Given this list of marker genes ALX4, GTF2IRD2, GLI2, DTYMK, DYNC2I1, EFNB1 (ephrin B1), PROKR2, SATB2, TBC1D20, CPLX1 (complexin 1), BRCA2, CHST14, HRAS, KISS1, PDPN, ALG8, ARID2, DAZ3, FMR1, ARL6, CHRM3 (cholinergic receptor muscarinic 3), BCOR, KMT5B, TBL2 (NCBI Gene Id 27203), IGBP1, SMC1A (structural maintenance of chromosomes 1A), MESP2, USP7, PHIP, OFD1, UQCC2, PRPS1, PEX12, CLCN3, POLD1, NFIB, MC2R, DPYSL5, STRA6, MRPS28, COMT, DNAJC21, HUWE1, PHACTR1, UBR1, FGF10, DYNC2I2, PSMD12, ARID1B, TRPM3, REST, LZTR1, SOX11, RAB3GAP1, SOX4, YY1, EIF4H, DAZ4, MKRN3, PDE4D, BBS4, CSPP1, CLCN4, PYCR1, PPP1CB, NHLH2, BIN1, MUSK, RPGRIP1L, KMT2E, RAB23, PAX2, TINF2, HPSE2, PIGG, PRKACB, ZBTB20, KDM5C, TRRAP, PPP1R15B, SDCCAG8, DYNC2H1, ATN1, RREB1, BBS9, VPS35L, KIF21A (NCBI Gene Id 80819), FGFRL1, STT3B, KIAA0753, TRIM32, TRIM28, ADAMTS15, PHGDH, VAC14, CCDC22, CYB5A, TRIP13, PRMT7, GTF2IRD1 (GTF2I repeat domain containing 1), PRIM1, COL4A1, OPHN1, KCNAB2, G6PC3, BBIP1, SMOC1, BDNF, MMP23B, XRCC4, IGF2, TAF4, SKI (SKI proto-oncogene), MRAP, SIN3A, TSR2, DUSP6, MADD, FANCD2, GFM2, CC2D2A, LAS1L, NDN, ALDH18A1, PTCH1, HS6ST1, DVL3 (NCBI Gene Id 1857), TIAM1, SEMA3A, SCAPER, LMBR1, WNT3, NCF1, ERCC4, VANGL1, TUBA1A, UBE4B, DVL1, POU3F3, LUZP1, HIBCH, EVC, MAPRE2, GATA5, SEC24C, PNPLA6, RNU4ATAC, SEMA3E (NCBI Gene Id 9723), SLC25A24, PDE6D, HNRNPK, ALDH1A2, FAM149B1, FGFR3, PEX2, LIMK1, RIPPLY2, POLR1A, NNT, ATP6V0A2, MTMR14 (NCBI Gene Id 64419), RAB3GAP2, DNM2 (dynamin 2), MAP2K2, ERCC6, BUB1B, WDR35, LETM1, ASH1L, FGF17, INSL3, GNB2, ITPR1, STX1A, GPR161, FLNB, ESS2, RTTN, XPC, MKS1, PEX14, EBF3, SIM1, EHMT1, NKAP, B3GALNT2, GPC3, TBX4, MBD5, TAF6, BRAF, DDB2, NKX2-6, GNRH1, PIK3C2A, FKRP, CEP120, DLL3, CRPPA (CDP-L-ribitol pyrophosphorylase A), BBS2, ANOS1, ZNF699, PIGA, SPRY4, CAMSAP1, MYF6, ARID1A, EED, CDCA7, MAPK1, RERE, SCYL2, ARCN1, DDX3Y, SOX2, PEX16 (NCBI Gene Id 9409), MAB21L1, NSMF, AR, FARS2, ZFPM2, SRD5A2, SRCAP, FLRT3, SNRPN, PTDSS1, RBMY1A1, PHF8, HSPG2, AKR1C2, GRIN2B, WT1, RIPK4, DDX3X, MAP2K1, BBS10, POLR3A, TPM2 (tropomyosin 2), SPATA22, ARNT2 (NCBI Gene Id 9915), JMJD1C, WNT7B, TOGARAM1, SGPL1, HS2ST1, LFNG, KCNQ1OT1, MKKS, CPLANE1, AKR1C4, SMCHD1, HES7, GP1BB, IFT80, SLC18A3, TMEM231, PHF6, CEP290, NDNF, PAX6, OTX2, HMGA2, RARB, THOC2, ROR2, DEPDC5, CHD7, LARGE1, POMK, SIX6, BUD23, GTF2E2, FANCE, FGFR2, PEX26, DNA2, KAT6A, ATP6V1E1, FRAS1, AHDC1, LIG4 (DNA ligase 4), POMGNT2, CREBBP, UBR7, EBP, GLI3, NOTCH3, NSUN2, HDAC4, HERC2, HESX1, HYMAI (hydatidiform mole associated and imprinted), EIF2S3, UFD1, MAD2L2 (mitotic arrest deficient 2 like 2), LMX1B, OTUD6B, FANCM, RPGRIP1, CDK8, PWAR1, PACS2, MASP1, MYMK, NR5A1, BBS7, H19, AARS1, ATAD3A, MYL11, ERCC3, ANKLE2, CEP19, FREM2, NAA10, RAD51C, ERCC2, FAT4, DHX37, UBE2A, PEX13, WBP4, MID1, ORC4, KISS1R, CDH11, RIT1, DKC1, ABCB7, BICRA (NCBI Gene Id 29998), RFC2, NF1, ABCD4, CDC45, NEDD4L, DGCR8, GNRHR, POMGNT1, MED11, PEX11B, PEX5, MAP3K7, ALKBH8, GRIA2, WNK3, TARS1, DLK1, CITED2, ATRX, MPLKIP, TMEM237, ODC1, BMP4, POLE, HNRNPR, KDR (NCBI Gene Id 3791), KDM3B, CHD4, RXYLT1, WNT5A, BRD4, GDF1, SNORD115-1, WNT7A, NXN, TXNRD2, RBM10, STT3A, RECQL4, DOK7, VPS50, OCRL, FLG, FBXL4, CARS1, RIN2, WWOX, SMAD4, TCF12, RAD51, SMC3, NONO, SETD5, SLX4, SOS1, PPFIBP1, RRAS, CCDC32, GK, FDFT1, DYNC2LI1, TNRC6B, NDUFB7, ABL1, POLR3K, NOTCH2, HNRNPH1, PTPRF, KMT2A, LHX4 (LIM homeobox 4), H4C9, WDR11, RSPO2, MYH3, CCDC174, POLA1, RYR1, SAMD9, POMT2, DGCR2, DPP9, GTF2H5, STXBP1, CTBP1, EP300, HOXD13, PEX3, METTL27 (methyltransferase like 27), MYLK, GATA1, SMS, GLI1, ATR, DDX59, SOX3, BBS5, MAP3K1, SLC16A2, LZTFL1, TBX22, RTL1, AMHR2, UBA1, GMPPB, TACR3, DAZ1, BRIP1, CYP17A1, JAG1, CWC27, BRF1, PLAGL1, OGT, IER3IP1 (NCBI Gene Id 55392), DAG1, LRIG2 (leucine rich repeats and immunoglobulin like domains 2), LHX1, TGDS, PBX1, NAF1, MEG3, MTOR, SIAH1, BBS1, USP9Y, PRDM13, SRY, ZMYM3, KIF7, DDX6, CYP11A1, TWIST2, TCOF1, ARVCF, FBN1, TMEM107, B9D1, POLR1C, GTF2I, PRKAR1A (protein kinase cAMP-dependent type I regulatory subunit alpha), ALG12 (ALG12 alpha-1,6-mannosyltransferase), MRAS, ADARB1, DSE, CILK1, DNMT3A, STAC3, PEX6, TBX3, RORA, AUTS2, IFT74, MEGF8, HBA2, RFWD3, FGF8, TSPYL1, GRB10, INPPL1, HBA1, TTC5, TCTN2, PAX7, FLNA, SPEN (NCBI Gene Id 348488), LSS, PIEZO2, GMNN, RRAS2, FBLN1, ANAPC1, GJA5, GPC4, KLHL15, JAM3, DPAGT1, TCTN3, FBXW7, DNAJC19, RLIM, CFAP418, TMEM67 (NCBI Gene Id 91147), RAC1, SMARCAL1, ESCO2, FLT4, XRCC2, SLC35D1, TBCE, KAT5, POLR1D, PACS1, OCA2, FEZF1, BRCA1, SNORD116-1, GRIP1, AMH, CAMK2A, CHRNG, CDC42, SHOC2, FANCL (FA complementation group L), TTC8 (tetratricopeptide repeat domain 8), KRAS, TCTN1, PAICS, PUM1, IFT27, FUZ, TCF4 (NCBI Gene Id 6925), ORC1, C2CD3, NSD2, DCC, RASA2, KANSL1, NPHP1, DHCR7, PORCN, NUP88, PEX1, SPECC1L, WDR62, NDP, ACBD6, RPL10, SCLT1, PTCH2, B4GAT1, MTM1, MBTPS2, SALL1, NIPBL, SLC26A2, GSC, CDH2, AEBP1, TOPORS, NALCN, SMARCA2, SRA1, SUZ12, HSD3B2, TBL1XR1, WDPCP, BRWD3, SOX9, HIRA, SLC30A7, CCDC141, CD96, ZSWIM6, CDC42BPB, POLR1B, APC2, AXL (NCBI Gene Id 558), SYNE1, RAB18, KDM5B, CDT1 (NCBI Gene Id 81620), ANK1 (ankyrin 1), ACTA2, GALT, ESAM, SMARCD1, DYRK1A, CLP1, ZFX, GATA4, KCNQ1, AFF4, CPE, TMEM70, TMEM94, SETBP1, TRIP4, CCBE1, CBL, TP63, MECP2, RNF135, B4GALT7, MYRF, TSPY1, VAMP7, ELN, ROBO1, HNF1B, TXNDC15, CUL4B, FBXO11, FILIP1, PSMC1, KMT2D, FANCC, DACT1, BAZ1B (bromodomain adjacent to zinc finger domain 1B), DIS3L2, PWRN1, HSD17B3, VPS37D, LMNB2, CDON, B9D2, PRKACA, FANCA, PIGS, SMARCB1, GPC6, FANCB, POGZ, WDR37, MAMLD1, EXT2, ADNP, SLC19A2, STS, GABRD, FANCG, MYOD1, ZNF462, HOXC13 (NCBI Gene Id 3229), RAPSN, FKBP6, CASZ1, GLE1, LONP1, NFIX, EZH2, FIG4, EMG1 (NCBI Gene Id 619532), KDM6B, ANKRD11, PIGN, IL17RD, MED12, DHODH, ERCC5, NPAP1, NRAS, TFAP2A, IRX5, ATP6V1A, FGFR1, XYLT2, RAC3, CEP152, MYH11, SEC23A, SMARCC2, FGD1, XPA, KDM1A, HDAC8, H1-4, DLX4, PALB2, ARX, TBCK, FANCF, SOS2, SOX5, TDRD9, PLAG1, TUBB, COL3A1, SUFU, ACTG2, IRF6, BBS12, EIF5A, KAT6B, CDC6, FTO, ASXL3, GRIA3, ACTB, PTPN11, MAGEL2, SOX10, SPRED2, RNF113A, POU6F2, OTUD5, TMEM270, ADAT3, KDM6A, TMEM216, MYT1L, NR0B1 (NCBI Gene Id 8238), BLM, ZMYM2, FXR1, CTCF, PPP1R12A, SMARCE1, PEX19, STAG1, MCM5, RAF1, NELFA, FLI1, TWIST1, AP1S2, FZD2, COG1, CHD6, ORC6, PROK2, MED13L, HYLS1, ERCC1, PRDM16, COLEC10, DAZ2, FANCI, MAF, MINPP1, DHDDS, MCTP2, ERCC8, VPS13B (NCBI Gene Id 54990), DGCR6, RAD21, ZEB2, B3GLCT, ALK, EVC2, CKAP2L, NKX2-5 (NK2 homeobox 5), POMT1, SMARCA4, PRKCZ, TBX1, PEX10, CDKN1C, PLVAP, IFT172, CLIP2, CYP19A1, POR, LMOD1, GATA6, DPF2, TOE1, FKTN, NSD1, UBE2T, COG5, TAC3, ZMIZ1, COLEC11, TASP1, STAR, DNAJC30, here is a description of the gene set: Cryptorchidism Human Gene Set: HP_CRYPTORCHIDISM studied in species Homo sapiens Testis in inguinal canal. That is, absence of one or both testes from the scrotum owing to failure of the testis or testes to descend through the inguinal canal to the scrotum.